The following is a description of a gene set: species: Mus musculus Any process that modulates the frequency, rate or extent of calcineurin-mediated signaling. Mouse Gene Set: GOBP_REGULATION_OF_CALCINEURIN_MEDIATED_SIGNALING, and this is the list of marker genes: Lmcd1, 3425401B19Rik, Homer2, Homer3, Chp1 (NCBI Gene Id 80510), Slc9a1, Efhb, Slc8a2, Tnf, Ppp3r2, Cherp, Mapk7, Cib1, Clec7a, Ppp3cb, Nrg1, Tbc1d10c, Mtor, Plcg2, Mir1a-1, Gsk3b, Mir1a-2 (NCBI Gene Id 723959), Erbb3, Actn3, Ppp3cc, Rcan1, Camta1, Ppp3r1, Sppl3, Nfat5, Nron, Dyrk2, Ptbp1, Cmya5, Myoz2, Ppp3ca, Chp2, Akap5, Atp2b4, Fhl2, Akap6, Prnp, Myoz1, Igf1